The following is a description of a gene set: studied in species Homo sapiens Human Gene Set: MODULE_171 Genes in the cancer module 171., and this is the list of marker genes: OAS1, HLA-A, IGLJ3, IL10RA, TNFRSF25, PLSCR1, CPVL, HLA-DRB3, CMKLR1, MAL, CMAHP, TRIM22, ISG20, CACNG4, SAMHD1, FOXP1, P2RY10, PNMA8A, GNLY, IL15, SYNE2, CEBPD, CD2, DBP, SLC40A1, GBP2, TTLL2, KLF6, IFI44L, CD8B (NCBI Gene Id 926), KCNA3, IL2RB, LAMP3, AQP9, POLR3B, HLA-DQA1, TNFSF10, IFT70A, HLA-DRA, IL3RA, SELP, CCL18, GMCL1, CARD16, STAT2, BANK1, CYP1B1, SLC7A7, RNF31, TNFAIP6, PPP1R16B, IFITM2, HELZ2, CCDC186, OAS3, MX2, MX1, HVCN1, CD200, LILRB1, CXCR6, USP30, IFITM1, CD14, THBS1, LGMN, PELI1, HLA-DQB1, CXCL13, ISG15, S1PR1, CD79A, CFB, UTY, DEFA1, ZNF292, IFI35, TREM1, IFITM3, PTTG1, KLRK1, IGHM, HLA-DPA1, TXLNGY, SELL, NEK11, MS4A1, ABTB1 (NCBI Gene Id 80325), SP110, CD3D, MCU, AXIN1, STAG3, IGHG3, PTPRCAP, ADAM19, CNRIP1, FADS1 (NCBI Gene Id 3992), CD48, FPR1, GBP1, UNC5D, HBA2, XCL1, IGKC, IL7R, SERPINA5, FAM53B, LPAR6, CAMK4, CCL7, SDC2, CSF3 (colony stimulating factor 3), TPTE2, IFIT1, CHST15, HLA-DPB1, SAMSN1, IFI44, KCTD12, KIAA0753, TCF7, TXNIP, VCAM1, CTSL, GZMA, NLRC5, PNPT1, STK31, CD5, LIMD2, IFIT5, KCNQ5, APOL3, CD86, CXCL9, RRP15, UNC79